The following is a description of a gene set: species: Homo sapiens The progression of a somite from its initial formation to the mature structure. Somites are mesodermal clusters that are arranged segmentally along the anterior posterior axis of an embryo. Human Gene Set: GOBP_SOMITE_DEVELOPMENT, and this is the list of marker genes: MTHFD1, SMO, FOXB1, KAT2A, PLXNA2, LHX1, SFRP2, LFNG, RBPJ, AXIN2, COBL, EPB41L5, SIX1, DLL1, NUP133, MIB1, TBX6, DMRT2, MYF6, GDF3, DLL3, TMED2, SMAD3, FOXC1, NRARP, TCF15, MED12, SHH, TCAP, EP300, PALB2, FOXC2, SFRP1, MSGN1, MYF5, ABI1, PCDH8, NLE1, TBXT, MEOX2, CRB2, CDX2, BMPR1A, SIX4, NKD1, PTCH1, POFUT1, CDX1, WNT5A, MESP1, RIPPLY1, TBX18, SMAD4, WNT4, FRZB (frizzled related protein), WNT1, WDR19, LOXL3, XRCC2, NOG, ZEB2, SEMA3C (NCBI Gene Id 222200), HES7, WNT11, TAF10, PSEN1, MESP2, POGLUT1, WNT3A, IHH, RBBP6, ATM, NKX3-1, RIPPLY2, PRKDC, SCX, NOTCH1, PPP2R3A, FOXF1, NCKAP1, DKK1, RAD51B, TP53, MEOX1, LEF1